The following is a description of a gene set: species: Mus musculus Mouse Gene Set: GOBP_FC_RECEPTOR_MEDIATED_STIMULATORY_SIGNALING_PATHWAY The series of molecular signals generated as a consequence of a the binding of the Fc portion of an immunoglobulin by an Fc receptor capable of activating or perpetuating an immune response. The Fc portion of an immunoglobulin is its C-terminal constant region., and this is the list of marker genes: Plscr1, Pten, Lyn (NCBI Gene Id 99963), Plscr2, Fcer2a, Appl1, Myo1g, Rapgef1, Ptprj, Nos2, Csk, Rabgef1, Fcer1g, Rap1a, Cd226, Cd47, Ptprc, Nr4a3, Appl2